The following is a description of a gene set: Human Gene Set: GOCC_MICROTUBULE Any of the long, generally straight, hollow tubes of internal diameter 12-15 nm and external diameter 24 nm found in a wide variety of eukaryotic cells; each consists (usually) of 13 protofilaments of polymeric tubulin, staggered in such a manner that the tubulin monomers are arranged in a helical pattern on the microtubular surface, and with the alpha/beta axes of the tubulin subunits parallel to the long axis of the tubule; exist in equilibrium with pool of tubulin monomers and can be rapidly assembled or disassembled in response to physiological stimuli; concerned with force generation, e.g. in the spindle. species: Homo sapiens, and this is the list of marker genes: MAPRE1, CLTC, ARHGAP4, TBCC, TUBB, TUBGCP6, RCC2, KIF1B, TEKT3, DCXR, KIF2B, GABARAP, KIF27, NDE1, MAP2, KIF18A, CFAP276, GAS2L1, DNAH6, PARP4, ODF2, CFAP90, ZNF207, KIF9, HSPH1, NDRG1, KIFC2, CLIP1, MACF1, FIGN, BCL2L11, PRC1, KIF26B (kinesin family member 26B), KIF2A, KIF2C, RASSF5, IQGAP1, SPMIP8, KLHL22, MAP1LC3B2 (microtubule associated protein 1 light chain 3 beta 2), RMDN2, DNAH1, LUZP1, KATNB1, GTSE1 (NCBI Gene Id 51512), CEP170B, DNM1, TPX2, CHMP4A, REEP4 (NCBI Gene Id 80780), TTLL1, MAP10, SPMIP6, DYNLT2, DNAH2, CCT5, NEK7, MEFV, KIF7, CLASP2, SNPH, LZTS2, TUBA1B, TBCE, HOOK3, TUBB6, MID1, SIRT2, MT3, HAUS2, SHTN1, DYNC1I2, CFAP95, CHMP6, RP1, CFAP126, STAU2, CNP, CHMP4C, CHMP5, CHMP7, TUBB3, TEKT4, EFCAB6, STMN1 (NCBI Gene Id 3925), KIF21B, CCDC66, CFAP52, CSPP1, DYNLT3, TUBA4A (NCBI Gene Id 93373), NME7, MAP7, EML3, CCT8, HNRNPU, ENKD1, EFHB, STIM1, TRIM54, SKA2, KATNAL2 (NCBI Gene Id 83473), SPAG8, APPBP2, SLC8A3, BIRC5, FAM110A, FGF13, CFAP96, TUBA4B, CDK1, EFHC2, FAM110C, ARFGEF2, FAM161A, CLASP1, MTA1, CAMSAP2, APC, SAA1, TPPP3, TTLL9, MTUS1 (NCBI Gene Id 57509), MID2, CEP170, KIF13B, ZWILCH, RASSF1, TUBB2B, CFAP206, TCP11L1, TUBB2A, MAP6D1, KIF23, AURKA, DCDC2C, TRPV4, DYNC2H1, SYBU, EMD, FHDC1, CIMIP2B, TEKTL1, MAP1B, CAMSAP1, DYNLRB2, EML1, AKNA, NUDC, KIF20B, DLG1, KIF24, EML4, HID1, TPPP2, CFAP68, CIMAP1D, KIF22, REEP1, CENPJ, KIF20A, TEKTIP1, CLIP3, MX2, CCT7, SAXO1, TMEM214, MAP2K2, KIF15 (NCBI Gene Id 56992), TTLL11, KIF4A, LRPPRC, KIF13A, NINL, PCNT, RASSF3, WHAMM, NCKAP5L, HAUS7, KIF26A, DNAH3, MAP1A, CAMSAP3, POLB, DYNLL1, SPAG5, KIF25 (NCBI Gene Id 3834), TTLL5, CIMIP2A, ASPM, KIFAP3 (kinesin associated protein 3), CHMP2A, CYP2A6, NUMA1, SPMIP10, SHROOM2 (NCBI Gene Id 357), TOGARAM1, CIMIP2C, DCDC1, KIF3A, SPEF1, CFAP77, MAP1S, RACGAP1, CDK5RAP2, DVL1, CHMP1B, KIF28P, TUBA1A, NIN, KIF21A, DST, CYLD, RP1L1, DISC1, CEP162, SPAST, DNAH12, KIF12, SKA1, MTCL1, TTLL13, MAPT, MAP7D2, ZNF804A, CALM2, DNAH9, SPAG6, HAUS4, TUBG2, DCTN2, BBLN, RIBC1 (NCBI Gene Id 158787), KLC3, PDE4DIP, SVIL, CFAP210, NAV1, NDEL1, MDM1, TUBB8B, CFAP107, SHROOM3, CENPE, CDK5, TEKT2 (NCBI Gene Id 27285), KIF17, CCT4, TUBD1, DNAL4, CCDC57, TUBA3E, CLMP, SPAG17, KIF5B, CALM1, DNAH11, TCP1, SARM1, TBCB, RUSC1, MAP1LC3C, CHMP3, GAS2L3, TUBGCP3, NEK2, BAG2 (NCBI Gene Id 9532), NCKAP5, PIERCE2, CHMP2B, ARL6, TRIM63, DNAH7, CCT6A, GRAMD2B, CFAP144, CFAP20, ATAT1, GAS8, GABARAPL3, CCT2, FBXW11, KATNAL1, TUBA3C, KLHL21, SLAIN2 (SLAIN motif family member 2), CCDC181, DYNLL2, MAP6, TUBG1, DNAI1, NICN1, KIF11, CAPN6, PBXIP1, DYNLRB1 (NCBI Gene Id 83658), CFAP45, TPT1, DNM2, DNAH14, DYNC1I1, CFAP141, HAUS5, NUSAP1, SHROOM1, AURKB, TUBGCP5, MX1, CKAP5, CFAP161 (NCBI Gene Id 161502), OPA1, KCNAB2, KNSTRN, EFHC1, CSNK1D, TEKT1, CFAP53, CCSAP, DYNC2LI1 (NCBI Gene Id 51626), DNAH17, CEP295, HOOK2, DCTN1, RADIL, LRRC49, GABARAPL1, IQGAP2, RMDN3, ZW10, TTLL3, RGS14, SRPRB, SAXO4, TTLL4, KIF14, ARHGEF2, BOD1, PIERCE1, FEZ1, DNM1L (NCBI Gene Id 692222), KIFC3, JAKMIP1, PSRC1, TUBB8, KIF1A, DCDC2, CHMP4BP1 (charged multivesicular body protein 4B pseudogene 1), MTCL2, ARL3, SEPTIN9 (NCBI Gene Id 8162), DYNLT1, FSD1, IFT70B, HDAC6, CALM3 (NCBI Gene Id 808), MAPRE3, CEP57L1, TUBGCP2, DNAH5, CASP1, DUSP21, SNTB2, DNAH10, KLC2, CEP57, EML5, SLAIN1, MAP3K11, AURKC, DCX, DYNC1LI2, DNAI2, SELENOS, DPP9, MAP1LC3B, TTL, EML2, PLK1, TTLL8, KIF1C, TBCD, KIF19, CCT3, TUBB1, SPMIP11, APC2, ARHGAP18, SPRY2, BEX4, KIFC1, RAB3D, SERP1, WDR47, TUBB4B, PYCARD, INCENP, TBCA, CLIP4, KIF3C, TUBA8, PACRG, KIF3B, IFT70A, RNF4, SAXO2, INVS, HAUS6, KIF5A, TUBA3D, CSTPP1, BAIAP2, ENKUR, HAUS3, BCL10, DYNC1LI1, NAV3, HAUS1, SCTR, RIBC2, TEKT5, DNAL1, CHMP4B, KLC1 (kinesin light chain 1), SPACA9, KIF18B, ABRAXAS2, EIF3A, DCDC2B, TPPP, RAB11A, SYNJ1, REEP3, MAP2K1, MTUS2, GOLGA2, WDR90, MNS1, GAS2L2, DNM3, CDK5RAP3, TUBAL3, TPGS1, DYRK1A, PTPN20, INO80 (NCBI Gene Id 84156, INO80 complex ATPase subunit), DPYSL2, CLIP2, EML6, RMDN1, KATNA1, KIF16B, CDK2AP2, MAP1LC3A, KIF6, TTLL6, MAP9, REEP2, DNAH8 (dynein axonemal heavy chain 8), TPGS2, SPMIP9, TUBE1, NEK6, CHMP1A, TUBB4A (NCBI Gene Id 1864), HAUS8, PAFAH1B1, FAM161B, BCAS3, SKA3, KIF5C (NCBI Gene Id 7860), DYNC1H1, TUBA1C, CUL3, MISP, CRHBP, MAPRE2, MATCAP1, CKAP2, MAP4, KNTC1, BICD1, TUBGCP4, TOGARAM2, TRIM55, KLC4, FKBP4, KIF4B (NCBI Gene Id 57056), HOOK1 (NCBI Gene Id 51361), MID1IP1, TTLL7